Given this list of marker genes Nupr1, Btg1, Pik3ca, Api5, Trp53, Socs1, Sfrp1, Pik3cg, Stk17b, Trp63, Ier3ip1, Bid, Cfdp1, Sirt1, Apc, Xrcc2, Men1, Gas6, Prdm11, Chd8, Ddias, Bcl2l11, Pmaip1 (NCBI Gene Id 58801), Bbc3, here is a description of the gene set: studied in species Mus musculus Any process that modulates the frequency, rate or extent of fibroblast apoptotic process. Mouse Gene Set: GOBP_REGULATION_OF_FIBROBLAST_APOPTOTIC_PROCESS